Given this list of marker genes CTNND1, PUS1, HSPG2 (NCBI Gene Id 7796), YARS2, FOXC2, CDH1, DLX4, TWIST2, PRR12, here is a description of the gene set: Human Gene Set: HP_DISTICHIASIS Double rows of eyelashes. studied in species Homo sapiens Distichiasis